The following is a description of a gene set: Genes down-regulated in LNCaP cells (prostate cancer) treated with forskolin, an activator of PKA pathway. Progression of prostate cancer to androgen independence is suspected to involve the androgen and protein kinase A (PKA) signaling pathways. Here for the first time, the transcriptomes associated with each pathway and common transcriptional targets in response to stimulation of both pathways were identified in human prostate cancer cells using Affymetrix GeneChip technology (Human Genome U133 plus2). Statistically significant changes in the levels of genes in response to androgen and genes in response to activation of the PKA pathway were determined using GeneSpring software. Expression of a subset of these genes (22) that were transcriptional targets for the androgen and/or PKA pathways were validated by reverse transcriptase-polymerase chain reaction and Western blot analyses. Application of small interfering RNAs to the androgen receptor (AR) revealed that in addition to KLK3, levels of expression of KLK2 and SESN1 were regulated by AR activated by both the androgen and PKA signaling pathways. SESN1 was identified as a gene repressed by activated AR. These results provide a broad view of the effects of the androgen and PKA signaling pathways on the transcriptional program of prostate cancer cells and indicate that only a limited number of genes are targeted by cross-talk between AR and PKA pathways. species: Homo sapiens from publication Wang G, Jones SJ, Marra MA, Sadar MD (PMID 16751804) Human Gene Set: WANG_RESPONSE_TO_FORSKOLIN_DN, and this is the list of marker genes: ATXN3, APPBP2, MAF, MTERF4, SLC30A7, NAV1, ZBTB10, SESN1, PIAS1